Given this list of marker genes Klc2, Rsf1, Tbc1d31 (NCBI Gene Id 210544), Uts2r, Galnt17, Irx2, Bivm, here is a description of the gene set: from publication Chen Y, Wang X (PMID 31504780) Genes predicted to be targets of miRBase v22 microRNA mmu_miR_132_5p in miRDB v6.0 with MirTarget v4 prediction scores > 80 (high confidence targets). species: Mus musculus Mouse Gene Set: MIR_132_5P